The following is a description of a gene set: Mouse Gene Set: GOMF_SMALL_PROTEIN_ACTIVATING_ENZYME_BINDING Binding to a small protein activating enzyme, such as ubiquitin-activating enzyme. studied in species Mus musculus, and this is the list of marker genes: Ube2i, Sae1, Uba2, Park7, Sumo1